Given this list of marker genes IL1B, ELOVL5, AVP, PTGS2 (NCBI Gene Id 5743), GPIHBP1, PLA2G3, MID1IP1, NR1H2, KAT2B, ABCD1, AVPR1A (NCBI Gene Id 552), ABCD2, NR1H3, APOC2, MIR182, APOA5, SLC45A3, LPGAT1, MIR96, APOA4, SIRT2, PLAA, MLXIPL, CD74, here is a description of the gene set: Any process that activates or increases the frequency, rate or extent of the chemical reactions and pathways resulting in the formation of fatty acids. Human Gene Set: GOBP_POSITIVE_REGULATION_OF_FATTY_ACID_BIOSYNTHETIC_PROCESS studied in species Homo sapiens